Given this list of marker genes Sos1, Snx1, Pigr, Fer, Efemp1, Socs5, Yes1, Plscr2, Itga5, Lingo1, Hbegf (heparin-binding EGF-like growth factor), Fam83b, Grb2, Cblc, Snx2, Btc, Shc1, Tgfa, Cd44, Vav2, Sla, Atxn2, Egf, Ms4a1, Cnot9, Ccdc88a, Areg, Snx4, Grap, Plscr1, Tnk2, Nrg2, Epgn, Erbb4, Agr2, Vav3, Arf4, Rnf126, Ereg, here is a description of the gene set: Binding to an epidermal growth factor receptor. Mouse Gene Set: GOMF_EPIDERMAL_GROWTH_FACTOR_RECEPTOR_BINDING species: Mus musculus